Given this list of marker genes LAMC1, SPANXN5, TTF2, TBX3, SENP5, PSMA3, TSNARE1, AFAP1L2, LGI1, TSHR, RAB5IF, RCOR1, MGAT4A, GABRG1, ERP29, DCAF8L1, GGT5, AGO1, CRIPT, TSLP, APPBP2, URI1, GPX2, EPB41L2, DENND3 (NCBI Gene Id 22898), ZFPM2, SPANXN1 (NCBI Gene Id 494118), TGIF2-RAB5IF, RAPGEF2, BEX4 (brain expressed X-linked 4), FILIP1L, REM2, GPR65, HYAL3, ZNF655, RAPGEF4, DMTN, PLAGL2, CEP78, EEIG1, N6AMT1, DOCK5, KCNMB1, PPP1R12B, CRH, here is a description of the gene set: Genes predicted to be targets of miRBase v22 microRNA hsa-miR-4515 in miRDB v6.0 with MirTarget v4 prediction scores > 80 (high confidence targets). Human Gene Set: MIR4515 species: Homo sapiens from publication Chen Y, Wang X (PMID 31504780)